The following is a description of a gene set: Mouse Gene Set: GOBP_UNSATURATED_FATTY_ACID_METABOLIC_PROCESS The chemical reactions and pathways involving an unsaturated fatty acid, any fatty acid containing one or more double bonds between carbon atoms. studied in species Mus musculus, and this is the list of marker genes: Mapk9, Cyp2d10, Cyp2j11, Acaa1a, Edn1, Cyp2j12, Cyp2c54, Scp2, Cyp2c55, Pla2g10, Cyp4a14, Tnfrsf1a, Atp6v1b1, Ptgr2, Cyp4a10, Gstm6 (glutathione S-transferase, mu 6), Alox12e, Akr1c19, Cyp4f13, Fads2, Cyp2a12, Gsta1, Avp, Edn2, Cyp2c40, Akr1b1, Ces2b, Ehhadh, Cyp2c37, Hsd17b4, Ces2e, Scd4, Ptges (prostaglandin E synthase), Elovl6, Ces2c, Ephx2, Ahr, Cyp2t4, Elovl3, Scd1, Cyp2g1, Cyp1a2, Sphk1, Cyp2a5, Akr1c6, Gpx4, Tmem135, Scd3, Dagla, Cyp2a4, Elovl7, Mgll, Elovl5, Ptgs2, Cyp2b23, Mgst3, Gstp1, Cyp2b19, Fabp5, Cyp4f15, Abcd1, Cyp2c23, Elovl2 (NCBI Gene Id 54326), Hpgd, Cyp1b1, Ptges3, Cyp2c29, Comt, Akr1c18, Pla2g2a, Fads2b, Akr1c20, Cyp4a32, Ces2h, Ptgr1, Alox8, Acox1, Cyp2f2, Alox12b, Sirt1, Cyp2d34, Gstm3, Daglb, Cyp4a12b, Pdpn, Plaa, Cyp2d11, Cd74, Cyp2d26, Alox15, Cyp2s1, Cyp2c38, Abcd2, Acaa1b, Gstp3, Akr1b7, Gstp-ps, Cyp4f18, Gstm1, Pla2g4a, Scd2, Cyp2j8, Cyp2j5, Gpx1 (NCBI Gene Id 14775), Ptgis, Hpgds, Ces2f, Cyp2d22 (NCBI Gene Id 56448), Sco1, Cyp2e1, Fads3, Ptgs1 (NCBI Gene Id 19224), Pla2g4f, Elovl1, Tbxas1, Cyp2j7 (cytochrome P450, family 2, subfamily j, polypeptide 7), Avpr1a, Cyp4a29, Cthrc1, Acsl4, Pla2g2f, Cyp2b9, Cyp2a22 (NCBI Gene Id 633450), Il1b, Mif, Cyp2c50, Ptges2, Cyp4f14 (NCBI Gene Id 80440), Elovl4, Cyp4a31 (cytochrome P450, family 4, subfamily a, polypeptide 31), Cyp4a30b, Ptges3-ps, Ephx1, Anxa1, Alox5, Cyp2b13, Cyp2j6 (NCBI Gene Id 13110), Cyp2j13, Alox12, Akr1c13, Cyp2b10, Pnpla8 (patatin-like phospholipase domain containing 8), Pibf1 (progesterone immunomodulatory binding factor 1), Acot8, Aloxe3, Pla2g3, Gstm7, Gstp2, Fads1, Cyp2u1, Cyp2c39, Ces2g, Cyp2d12, Akr1c14, Decr2, Acsl1, Cyp2j9, Ptgds, Prxl2b, Cyp4a12a, Akr1cl, Cyp2d9, Akr1c12, Ces2a (carboxylesterase 2A), Cyp4f40, Akr1c21